The following is a description of a gene set: species: Homo sapiens Type 1 IFNs can conditionally activate all of the signal transducers and activators of transcription molecules (STATs), including STAT4. The best-characterized signaling pathways use STAT1, however, and type 1 IFN inhibition of cell proliferation is STAT1 dependent. We report that type 1 IFNs can basally stimulate STAT1- and STAT4- dependent effects in CD8 T cells, but that CD8 T cells responding to infections of mice with lymphocytic choriomenigitis virus have elevated STAT4 and lower STAT1 expression with significant consequences for modifying the effects of type 1 IFN exposure. The phenotype was associated with preferential type 1 IFN activation of STAT4 as compared to STAT1. Stimulation through the TCR induced elevated STAT4 expression, and STAT4 was required for peak expansion of antigen-specific CD8 T cells, low STAT1 levels, and resistance to type 1 IFN-mediated inhibition of proliferation. Thus, a mechanism is discovered for regulating the consequences of type 1 IFN exposure in CD8 T cells, with STAT4 acting as a key molecule in driving optimal antigen-specific responses and overcoming STAT1-dependent inhibition of proliferation. Genes up-regulated in CD8 T cells: wildtype versus STAT4 knockout. Human Gene Set: GSE40666_WT_VS_STAT4_KO_CD8_TCELL_UP from publication Gil MP, Ploquin MJ, Watford WT, Lee SH, Kim K, Wang X, Kanno Y, O'Shea JJ, Biron CA (PMID 22968462), and this is the list of marker genes: C11orf97, PLXNC1, DDI1, H1-8, HECTD1, CCDC85C, RAB10, CERS4, UTS2R, KLK4, SFRP1, WNT9B, CACFD1, DICER1-AS1, TMEM238, DOC2A, SFTPC, PKP2, EPHA5-AS1, SPRY1, GALR3, LINC01854, TMEM61, MAGEA4, KCNQ1OT1, CROCCP3, GABRA1, FAM170A, LINC02028, DUSP15, GJD3, NFE2, SLC25A41, DUOXA1, MATN1, SLC8A2, MARCKS, PHF21B, EPSTI1, DLEC1, WNT1, CCR10, FAM24A, HABP2, CHRDL2, GPR6 (G protein-coupled receptor 6), C4BPA, PAX2, NEO1, ACACB, KLF12, TCL1A, TMEM204, CBLC, TDRD7, RTP3, KRT19, SEMA3F, EPHB4, FAM9C, DBH, MAGIX, ZBTB17, CYLC2, JSRP1, RETREG1, LINC01348, NKX2-1, MIXL1, LINC02685, PCDHGA3, HOXB9, JAM2, PLVAP, AQP10, GNAL, GATA6, RPS6KA6, MLPH, SCNN1G, ALPI, TNFAIP2, VWA5B2, PRRT2, HBQ1, CPXM1, TPSG1 (tryptase gamma 1), HRH3, CSF3, DDC, ANO7L1, PHOSPHO1 (NCBI Gene Id 162466), ENSG00000284948, PCDHB6, NTSR1, POLN, NGF, ZNF653, PIM1 (NCBI Gene Id 82453), PGGHG, CFAP206, SLC1A2, LITAF, PANX2, IL4, CLDN20, SLC7A13, HLA-F, ATF7IP, HAPLN1, TBX5-AS1, ZNF395, KCNH1, SEMA4C, KMT2D, SMPD2, MX1, FHAD1, SMOC1, KRT2, ZNF831, MSANTD3, GVQW3, SDCBP2, SSTR2, CACNA1G (calcium voltage-gated channel subunit alpha1 G), GAL3ST2, PCDHGA8, HAND2, E2F4, PCARE, LYST, TEX29, CCDC70, NUPR1, KCNK10, SEMA3C, MIR124-2HG, PTGDR2, CALHM5, UBE2QL1, PPP2R3B, STAT1, SCUBE1, NLRC5, CCNA1, CALN1, NGB, NKD1, MCF2L-AS1, CYRIA, TESMIN, CNFN, ANO8, NRP2, FBXL19-AS1, NODAL, ACOT9, SNORA74A, COL17A1, CCK (NCBI Gene Id 885), GREP1, MAPT, GRIK1-AS1, OR10C1, RNASE11, FAM187B, BPIFB2, DIRAS2, GRK5, DHX58, GUCY2D, GUCY1B2, PKD1L2, MMP28 (matrix metallopeptidase 28), TBX2, GRIK4, ZBTB32, LMCD1, MYOCD, CELP, LINGO3, NTNG1, FBXO24, KLLN, IL1RAPL1